Given this list of marker genes RPS23, EEF1A1, RPL6, FAU, PABPC1, UBB, RPL13, RPS12 (NCBI Gene Id 6206), RPL3, RPS19, GPR161, NACA, RPLP0, RPS25, RPS3A, BTF3, RPL18, RPS4X, ZFPL1, RPL38, RPL7 (ribosomal protein L7), RPS9, LYPLA2, RBM3, RPL36A (ribosomal protein L36a), RPLP2, RPL34, RPL31, RPS13, RPL28, TUBA1B, OAZ1, H3-3A, RPL11, RPL17, EEF1G, PTMA, ARAF, RPS14, YBX1, RPL32, RPL10A, RPL23, SLC25A6, UBC, RACK1 (NCBI Gene Id 90938), RPL37, RPS6, RPS18, EIF4G2, EEF2, RPS11, RPL12, RPS24, RPL22, HNRNPK (heterogeneous nuclear ribonucleoprotein K), SUMO2, RPL21, RPL8 (ribosomal protein L8), RPL13A, RPS27A, RPL15, RPS8, RPL9, RPLP1, PPIA, SRP14, RPS20, RPS16, NPM1, RPL5, RPL27A, RPL19, TPT1, RPL18A, PGK1, RPL10, RPS7, ACTG1, COX7C, EEF1B2, RPL29, PCBP2, RPS10, RPS27, RPL23A, RPS29, RPL27, ACTB, RPS5, RPL24, EIF4A2, RPL30, CFL1, B2M, RPL4, RPS17, RPS3, RPS15A, RHOA, JUND, MYL6, here is a description of the gene set: Human Gene Set: MORF_TPT1 Neighborhood of TPT1 studied in species Homo sapiens Neighborhood of TPT1 tumor protein, translationally-controlled 1 in the MORF expression compendium